Given this list of marker genes DYNLT2B, HSP90AB1, DNAI2, RUVBL1, DNAAF3, DNAI4, NME9, DNAAF4 (dynein axonemal assembly factor 4), DNAAF5, WDR18, DNAAF10, DNAAF2, DNAAF8, SPAG1 (NCBI Gene Id 6674), DNAI1, RUVBL2, ZMYND10, DNALI1, DNAAF11, STIP1, here is a description of the gene set: species: Homo sapiens An aggregation of axonemal dyneins, their specific assembly factors, and broadly-acting chaperones that is located in the cytoplasm. Human Gene Set: GOCC_DYNEIN_AXONEMAL_PARTICLE